The following is a description of a gene set: Genes up-regulated in SKOV3ip1 cells (ovarian cancer) upon knockdown of EZH2 by RNAi. Although VEGF-targeted therapies are showing promise, new angiogenesis targets are needed to make additional gains. Here, we show that increased Zeste homolog 2 (EZH2) expression in either tumor cells or in tumor vasculature is predictive of poor clinical outcome. The increase in endothelial EZH2 is a direct result of VEGF stimulation by a paracrine circuit that promotes angiogenesis by methylating and silencing vasohibin1 (vash1). Ezh2 silencing in the tumor-associated endothelial cells inhibited angiogenesis mediated by reactivation of VASH1, and reduced ovarian cancer growth, which is further enhanced in combination with ezh2 silencing in tumor cells. Collectively, these data support the potential for targeting ezh2 as an important therapeutic approach. Human Gene Set: LU_EZH2_TARGETS_UP from publication Lu C, Han HD, Mangala LS, Ali-Fehmi R, Newton CS, Ozbun L, Armaiz-Pena GN, Hu W, Stone RL, Munkarah A, Ravoori MK, Shahzad MM, Lee JW, Mora E, Langley RR, Carroll AR, Matsuo K, Spannuth WA, Schmandt R, Jennings NB, Goodman BW, Jaffe RB, Nick AM, Kim HS, Guven EO, Chen YH, Li LY, Hsu MC, Coleman RL, Calin GA, Denkbas EB, Lim JY, Lee JS, Kundra V, Birrer MJ, Hung MC, Lopez-Berestein G, Sood AK (PMID 20708159) studied in species Homo sapiens, and this is the list of marker genes: PHF5A, NCAPH2 (non-SMC condensin II complex subunit H2), GARIN5A, COMTD1, OXLD1, STUB1, RPAIN, ALKBH2, ENDOG, IFIT1, TAF15, MEX3D, MYH4, MYL6B, TMEM216, HSCB, ISCA1P1, THOC3, ELOB, TRIOBP, C1orf50, GNA11, S100A2, PFDN6, SNCG, TEX19, RCC1L, NME2, MCRIP2, BOK (BCL2 family apoptosis regulator BOK), RHOF, TMEM30A, G3BP2, CBY1, PEX16, CFD, RARRES2, HES4, ZNF616, TSPAN17, ECHDC3, RGS19, MIEN1, CCDC107, F11R, NENF, CPM, DENND2A, OSBPL5, TPM4, THOC6, TOMM22, CLIC3, TRAPPC12, PLEKHJ1, TYSND1, OCEL1, ZNF814, PAGR1, ISOC2, GSDMA, NDUFA8, DLK2, ZP3, PSMB8, HSDL2, ADAMTS4, LONP1, ARL17B, C17orf49, RPL36, FAM222A, HNRNPA3, BEND4, TMEM141, GUCD1, TCF20, RAD51D, OASL, PAQR7, SNHG10, BST2, RPS6KB2, MTX1, PRSS23, OGG1 (8-oxoguanine DNA glycosylase), FLOT1, PARD6A, MFSD3, ZNF629, PPIL6, APOBEC3F, GANAB, SURF2, HCFC1R1, IFIT3, ZNRD2, CSH1, PPP1R1B, CLDND2, REEP5, S100A13 (NCBI Gene Id 6284), STK19, TRIM47, RPL13AP6, COX14, ETFB, CHST14, HAGHL, CASP7, CGB8, ZNF589, LSM7, LMNA, PCK2, HABP4, KRTCAP2, AMDHD2, HDAC1, SNHG11, ACO2, CSK, PSMB10, WDR83, LAMTOR4, CYTOR, IFT43, CAVIN3, SDHC, NME3, TES, ENSA, KLHDC9, ARHGAP21, RPUSD1, HSD11B1L, TLCD1, TRAPPC5, AKR1C2 (aldo-keto reductase family 1 member C2), PLAAT4, HYAL3, TOR3A, SH3GL3, CENPV, SPANXD, SERF2, SIGIRR, TEDC1, MAPKAPK3, ADAP1, VOPP1, KLHL35, UQCR10, NUDCD3, GFOD2, SLC25A26, B4GALT1 (NCBI Gene Id 2683), SKA2, POLR2C, MAPK11, G0S2, ZDHHC16, IFI27, CRYBB2 (crystallin beta B2), RUVBL1 (NCBI Gene Id 8607), MATK, FOXK2, SNHG32, IFI35, WDR54, WASH2P, IER3, ZNHIT1, S100A4, PRIM2, JOSD2, RMND5B, AP1S1 (NCBI Gene Id 574017), TRIM16L (NCBI Gene Id 653524), HYAL2, HBQ1, ZNF133, MRFAP1L2, EMC6, ATOX1, SLC6A10P, PHGDH, AVPI1, DDIT3, TUFT1, OGFR (NCBI Gene Id 51783), PSMC3, RPS19BP1, TM4SF1, GCHFR, AHNAK2, ISG15, STYXL1, UBE2L6, UNC45A, BCAS4, ZW10, NAA38, HDGFL2, ZCCHC3, FGA, LMTK3, RNASEH2CP1, BEX3, TRIB3, H2AC20, ARTN, PSMB7, SCAND1, TEAD4, ELFN2, MSRB3, CYP1B1, CGB5, MPG, C8orf82, DPM3, MAFA, PSMB9, LY6H, SDC4, CD68, SHARPIN, TLK2, CCDC32, CDK9, FNBP1, PPP3R1, PRMT6, S100A6, PDXP, PIH1D1, TP53BP2 (tumor protein p53 binding protein 2), PMVK, CUTA, GALT, PGAP3, PPP1R14B (NCBI Gene Id 26472), PRDX4, FAM25EP, LPCAT1, ODF2, RPLP0P6, PPP2R2A, GATD3, MICAL2, ZCCHC24, DDIT4, CBR1, SOD2, NUDT1, WDR74, KLHDC3, C6orf226, PCNX3 (pecanex 3), PPFIBP1, WDR45, TMEM217, TRIP6, AZIN2, FAM219B, TESK1, IRF7, AOPEP, ZMAT5 (zinc finger matrin-type 5), PITX1, PSMD4, MKNK2, FAM25A, BIK, C1orf210, NOLC1, NES, CLDN7, PFKL, NEURL3, MGMT, PODXL2, C2CD2, AHSA1, H2AJ, CYB561D2, PUSL1, PHF19